The following is a description of a gene set: Enlargement of the thymus. Human Gene Set: HP_THYMUS_HYPERPLASIA Thymus hyperplasia studied in species Homo sapiens, and this is the list of marker genes: NUAK2, MTHFR, AKT1, VANGL2, ALG14, PTEN